Given this list of marker genes MEFV, ADAMTS15, PRDM12, SEPTIN9, KRIT1, SERPING1, MYORG, LZTR1, ATL3, NF2, NFU1, PRORP, LITAF, CCM2, SPTAN1, COQ6, POLG, KIF1A, PDCD10, FGD4, SMARCB1, TYMP, ATP7B, PMP22, PIK3CA, TWNK, here is a description of the gene set: Hypoesthesia Decreased ability to perceive touch. Human Gene Set: HP_HYPOESTHESIA species: Homo sapiens